Given this list of marker genes RUNX1, KCTD6, CBFB, GPAM, AXIN1, ESR1, here is a description of the gene set: RUNX1 regulates estrogen receptor mediated transcription Human Gene Set: REACTOME_RUNX1_REGULATES_ESTROGEN_RECEPTOR_MEDIATED_TRANSCRIPTION studied in species Homo sapiens